Given this list of marker genes Stim2, Plcg2 (NCBI Gene Id 234779), Asph, Casq1, Ubqln1, Cracr2a, Stimate, Stim1, here is a description of the gene set: Mouse Gene Set: GOBP_REGULATION_OF_STORE_OPERATED_CALCIUM_CHANNEL_ACTIVITY Any process that modulates the frequency, rate or extent of store-operated calcium channel activity. studied in species Mus musculus